Given this list of marker genes LDHA, PKM, GAPDH, G6PD, ENO1, RB1, PGK1, HK1, ALDOC, TP53, PRKAA1, here is a description of the gene set: Glycolysis in senescence Human Gene Set: WP_GLYCOLYSIS_IN_SENESCENCE species: Homo sapiens